Given this list of marker genes SMARCA4, MYC, ARID2, NFE2, SMARCB1, SMARCC1, H2AC25, SMARCD3, SSRP1, SUPT16H, ATAD2B, ATAD2, SMARCD2, GRWD1, RPL23, HMGA1, H2BC1, ARID1A, SET, SMARCC2, SMARCD1, SMARCE1, TNP1, here is a description of the gene set: species: Homo sapiens The disaggregation of a protein-DNA complex into its constituent components. Human Gene Set: GOBP_PROTEIN_DNA_COMPLEX_DISASSEMBLY